Given this list of marker genes AACS, BDH2, BDH1, ACAT1, HMGCL, OXCT2, HMGCLL1, ACSS3, HMGCS2, OXCT1, here is a description of the gene set: studied in species Homo sapiens Human Gene Set: REACTOME_KETONE_BODY_METABOLISM Ketone body metabolism